The following is a description of a gene set: species: Mus musculus Mouse Gene Set: GOBP_CALCIUM_MEDIATED_SIGNALING Any intracellular signal transduction in which the signal is passed on within the cell via calcium ions., and this is the list of marker genes: Cd8a, Grik2, Rit2, Selenok, Slc8a1, Myh7b, Cxcr5, Cib1, Calm1, 3425401B19Rik, Grik1 (glutamate receptor, ionotropic, kainate 1), Tmbim1, Ccr6, Htt, Cxcr4, Dmpk, Prkd1, Mapt, C3ar1, Cd3e, Nfat5, Kcnj8, Cd22, Pkd2, Exoc4, Irgm1, Trem2, Gria3, Mcu, App, Grm1, Defb1, Ryr2, Rcan1, Nfatc4, Atp2b4, Pdk2, Fpr-rs7, Tff2, Tox3, Trat1, Syk, Ptgdr2, Gsk3b, Sla2, Myoz1, Ccrl2, Negr1, Adora3, Calcr, Atp2a2, Ackr4, Hdac4, Sgcd, Gria1, Mapk7, Jpt2, Mtor, Atp1a3, P2rx4, Itpr3, Tnfsf11, L1cam, Casq2 (calsequestrin 2), Nr5a1, Tbc1d10c, Cacna1d, Grin1, Bnip1, Ppp3r2, Ccl20, Oprl1, Tmbim4, Ksr2 (NCBI Gene Id 333050), Nron, Igtp, Car8, Samd14, Nfatc2, Cd24a, Cxcr6, Ackr2, Avpr1a, Edn2, Ncald, Drd1, Tmem100, Plcg2, Cacna1c, Hpca, Gna15, Ccr10, Sppl3, Ccr9, Nfatc1, Igf1, Prnp, Actn3, Neurod2, Homer2, Ackr3, Lhcgr, Cxcr1, Ptprj (protein tyrosine phosphatase receptor type J), Ednrb, Cabyr, Efhb, Trpm2, Fkbp1b, Ramp3, Chp1, Itpr2, Homer3, Trpa1, Hint1, Slc9a1, Trpm4, Calm2, Rgn, Ppp3cb, Grin2b, Camta1, Mir1a-1, Cmya5, Egln1, Ccr3, Tprg1l, Pdgfra, Nfatc3, P2ry12, Kcnj11, Erbb3 (NCBI Gene Id 97627), Dmd, Ncs1, Tnni3, Lrrk2, Ncam1, Fpr2, Ccr1l1, Ccr5, Agtr1a, Edn1, Ccr2, Kdr, Ccr4, Ccr7, Itpr1, Pln, Tpcn2, Rcan3, Akap6, Irgm2, Zap70, Grik3, Nrg1, Drd4, Fpr-rs3, Ada, Plcg1, Fpr-rs4, Fpr-rs6, P2rx1, Bhlha15, Grm5, Camkk2, Defb37, Clec7a, Siglecg, Atp1b1, Akap5, Casq1, Alms1, Pdgfrb, Trpv1 (NCBI Gene Id 22366), Nr5a2, Cyp19a1, Calm3, Ryr3, Kiss1r, Ppp1r9a, Gpr62, Chrm3, Ppp3r1, Cd4, Cdh13, Nfam1, Grin2d, Cxcr3, Slc8a2, Nmur1, Slc24a4, Cherp, Pdpk1, Ryr1, Htr2b, Cxcr2, Ptbp1, Xcr1 (chemokine (C motif) receptor 1), Chp2, Itgal, Ppp1r9b, Adgrb2, Zmpste24 (NCBI Gene Id 230709), Sphk1, Bst1, Cx3cr1, Lmcd1, Cp, Agtr1b, Lat, Grin2a, Tmem38b, Ccr8, Ank2, Dyrk2, Mir1a-2, Dyrk1a, Ccl3, Fhl2, Pomc, Orai1 (ORAI calcium release-activated calcium modulator 1), Myoz2, Mcoln1, Prkaa1, Tmem38a, Cmklr1, Sco1, Iapp, Treml1, Lat2, Tpcn1, Rem1, Tnf, Eif2ak3, Pcp4, Ppp3ca, Rcan2, Ccr1, Fcer1a, Ptprc, Ppp3cc, Htr2c